Given this list of marker genes CSF1R, ABCB8, INA, NMT2, FNTB, SLC12A5, ETV5, ELN, PECAM1, DIPK2B, SEC61G, ARSA, NEFH (neurofilament heavy chain), C4BPB, ZNF160, NT5DC2, SLC23A2, EPB41L2 (erythrocyte membrane protein band 4.1 like 2), DOCK1, ZC3H3, SHLD2, H3C4, PLEKHB2, ACBD6, PHYHIP, SMG5, CRY1, HOXD1, MIF4GD, DNAH11, PKD1, SARS1, AVIL, ASB16, NUP88, ADCY7, RSF1, PRSS2, DGAT2, ST7L, ZNF106, TRIP12, KDM7A, NR1H3, CHAMP1, TAF7, INPP5B, PTH1R, IL1RL1, PSMD7, PAK1IP1, WNT2, TPT1, here is a description of the gene set: Human Gene Set: MODULE_166 Genes in the cancer module 166. species: Homo sapiens